The following is a description of a gene set: Human Gene Set: WP_ACUTE_MYELOID_LEUKEMIA studied in species Homo sapiens Acute myeloid leukemia, and this is the list of marker genes: NFKB1, JUP, MAPK1, AKT1, PIK3R2, AKT3 (AKT serine/threonine kinase 3), CCNA1, MYC, CEBPE, PIK3R3, BAD, AKT2, CEBPA, MAP2K1, PIK3CB, CD14, ITGAM, MPO, SOS1, STAT3, BRAF, CCNA2 (cyclin A2), SOS2, BCL2A1, IKBKB, LEF1, STAT5B, PIM2, CHUK, NRAS, PIK3CD, TCF7, MAPK3, ARAF, PIK3R1, STAT5A, SPI1, KIT, MAP2K2, PML, PPARD, IKBKG, TCF7L1, CSF1R, PIM1, FLT3, KRAS, RAF1, HRAS, RUNX1, RARA, RUNX1T1, RPS6KB1, FCGR1A, RPS6KB2, RELA, PIK3CA, PER2, GRB2, ZBTB16, CCND1, MTOR, DUSP6, EIF4EBP1, TCF7L2, CSF2, GLI1, IL3